Given this list of marker genes GALR1, GAL (NCBI Gene Id 51083), CRH, DAB2, C1QTNF1, GHRL, ECRG4, BMP6, TAC1, here is a description of the gene set: Any process that activates or increases the frequency, rate or extent of corticosteroid hormone secretion. Human Gene Set: GOBP_POSITIVE_REGULATION_OF_CORTICOSTEROID_HORMONE_SECRETION studied in species Homo sapiens